Given this list of marker genes EDC4, GTF2A1L, RGS8, ADAMTS3, LBX1, SEZ6, SEMA3A, GAP43, ASCL4, PLPP3, COMMD10, KRT23, MINK1, PSMA1, B3GALT1, SHOX2, HTR2C, SULF2, DDX5, STAT3 (NCBI Gene Id 6774), JPH3, MAPK8, SOX5, HERPUD2, NLGN2, DLX1, BMP1, ABHD17B, FEZF2, ZNF804A, ITPR3 (NCBI Gene Id 3710), KAT6B, LYPD1, LRFN5, PRKAB1, HESX1 (NCBI Gene Id 8820), ZFPM2, CGA, MMP27, PHC2, TAC1, NPAS3, SIX1 (SIX homeobox 1), CCNJ, CXCL14, OGT, GSE1, NPEPL1, PTH1R, PRKACA, INPP5F, EBF2, ASF1A, IKZF5, BMP5, OVOL1, PRDM8, ZNF148, PIPOX, ACP6, HOXC4, MITF, KRT85, NFATC4, PIK3R3, ADAM11, UBA3, FOXP1, SH3BGRL2, DIO2, CLDN17, SYT9, ARHGEF38, DIXDC1, TSHZ2, XYLT2, SEL1L3, SCN3A (sodium voltage-gated channel alpha subunit 3), PDE3B, GPRC5C, OPRM1, NOL4L, JAZF1 (JAZF zinc finger 1), LAMB1, PRRX1, LRRC4, SLC6A15 (solute carrier family 6 member 15), FST, FIGN, PRPF38B, PARD6G, HOXB7, ZBTB20, GRM5, TESK2, HOXC6, KLK13, INPPL1, TXLNG, GRWD1, LRRTM1, SLC39A14, LDB2, LINC01164, RALGPS2, CNTNAP4, DSPP, CNTLN, ANK2, BMAL1, OSR2, ST8SIA3, TMTC2, HRK, KCNS1, PROP1, BTBD3, PURA, MYT1, CEP120, HOXA9, SYTL2, PRSS12, LINS1, ZRSR2, TTLL6, MEIS1, IL17F, DNAJC5B, LMO3, SIAH3, TMEM94, HAS2, CALD1, STC1, LINC03122, MBNL1, CNN3, PCNT, CLDN8, DMD, IRX6, HOXB6, KCTD15, DCT, FOSB, ESR2, WNT8B, DEDD, SLC10A7, ZNF423, ITGA11, HOXD8, RFX8, GRPR, PAQR9, CEP95, LCP1, NRP1 (NCBI Gene Id 8829), GBX2, MS4A1, SLC25A25, EHF (NCBI Gene Id 26298), ARID3B, PECR, POLE2, SIX3, SALL3, HPSE2, SYNRG, FAM53B, TP63, PRG4, CLSTN2, ZEB2, MTUS1, RTL9, MAB21L1, HOXA7 (NCBI Gene Id 3204), CD36, SSH2, ALKBH5, CLRN1, TRIM24, PREX2, CYFIP2, EFNB3, POGZ, ZFHX4, RUNX1T1, FBLN2, MEF2C, MCTS1, EFNA5, SLC26A7 (solute carrier family 26 member 7), PHOX2B, CS, RORB, PRDM12, ARHGEF10L, RNF11, SLC24A4, TRPM1 (NCBI Gene Id 4308), RREB1, TBX6, ACADSB, RFX3, ASB7, TYR, OTX2, LUC7L3 (NCBI Gene Id 51747), UVRAG, GEN1, IRX4, GCNT2, TMEM169, GRIN2A, LEMD1, TCAP, PRR34, RNF122, NRXN1, KRTAP11-1, KRT32, ATXN7L1, SEZ6L, PPP1R2B, HEY2, PDZRN4, MLLT10, TLE4, PPP1R16A, ONECUT2, TAS2R7, KCNK2, FAM169BP, TRPM8 (transient receptor potential cation channel subfamily M member 8), BARHL2, CELF2, DSCAM, SLC24A2, ETV1, EOMES, SOCS5, CTNND1, NEO1, LIX1, here is a description of the gene set: Human Gene Set: S8_01 studied in species Homo sapiens Genes having at least one occurrence of the motif WNNANYYAATTANCNN in the regions spanning 4 kb centered on their transcription starting sites. This matches the PRRX2 transcription factor binding site V$S8_01 (v7.4 TRANSFAC).